Given this list of marker genes ARHGEF7, CAMKK2, CALM1, GIT1, RAC1, CAMKK1, CAMK1, here is a description of the gene set: studied in species Homo sapiens Reactome Pathway: Activation of RAC1 downstream of NMDARs Activation of calcium/calmodulin-dependent kinase kinases, CaMKKs (CAMKK1 and CAMKK2), upon calcium influx through activated NMDA receptors, leads to activation of the cytosolic calcium/calmodulin kinase CaMKI (CAMK1). One of the CAMK1 targets is the RAC1 guanine nucleotide exchange factor ARHGEF7 (beta-Pix). Activation of RAC1 is involved in NMDA-receptor triggered synaptogenesis. part of: Post NMDA receptor activation events